Given this list of marker genes CD74, PHF13, GLCE, BLTP1, INTS15, SENP6, IER5, ZFP62, TRIM33, FASTKD2, NFKB2, TAP1, TOR1AIP2, CLMP, IQGAP2, GBP6, ADORA2A, NUBPL, IL1RN, IL36A, SPATA2, HDC, VEZF1, TNNI3, IL15, C10orf88, TAF7, UTP20, E2F5, HMGN5, ORM1, POLR1F, SNN, PES1, EIF3D, CSF1, AMMECR1L, MECR, ARF1, RPS6KA5, RPS6KA2, MED21, BAZ1A, CH25H, PTPRC, CYTL1, FUS, CLIC4, MRPL10, SRRM2, SFR1 (NCBI Gene Id 119392), ARSG, COG3, MIR22HG, LAMC2 (laminin subunit gamma 2), NFKBIE, HSPA1L, JDP2, NDUFS1, ATF6B, CALHM6, ING3, ANKRD11, MTMR12, GBP7, DNAJC1, CLCN7, ENPP4, RELB, FGG, TES, FSCN2, TTC5, ADCY10, LONP1, TRAK2, CCSER2 (coiled-coil serine rich protein 2, NCBI Gene Id 54462), ZRANB1, PHLDA1 (pleckstrin homology like domain family A member 1), LRCH1, SNRPB, RAVER1 (ribonucleoprotein, PTB binding 1, NCBI Gene Id 170590), ZNF800, LENG1, GAB2, ANTXR1, PRSS46P, KMT5A, MSANTD4, MRPL50, CDKN1A, SLC25A37 (NCBI Gene Id 55881), IL1RAP (interleukin 1 receptor accessory protein), MDM2, KCNE4, CPSF7, RDH13, HBP1, CHIC2, HS6ST2, NGLY1, RAD18, SAP30, MAP2K4, DCAF12, CLOCK, HIVEP3, TXNL1, CISH, TLR1, MAP3K8, JUND, FBXO34, UFM1, MED19, SUN2, SLC30A6, NCK1, GUCD1, MCOLN2, CCDC157, CGAS, ADGRD1, NSUN5, MAPK1, NOP14 (NCBI Gene Id 8602), NFKBID, IPO7, RIMOC1, ADORA2B, CLBA1, RNF4, TSHZ1, ZNF827, ELF2, TIMM23, UBQLN1, CTDNEP1, CSF3 (colony stimulating factor 3), NDST1, PEX16, SUPT7L, TMF1, ZNF655, PHF12, CHD2, RNF180, RABAC1, CASKIN2, NFKB1 (NCBI Gene Id 4790), KDELR1, OSM, COL18A1, F2R, TBC1D1, IL12B, BLZF1, NAP1L4 (nucleosome assembly protein 1 like 4), PAK4, ETS1, CLEC4E, FAM120AOS, EIF2S2, HMGB2, FLNB, KCMF1, RNF146 (NCBI Gene Id 81847), SLC20A1, TMEM161B, MERTK, UBL4A, PRPS1L1, MAK16, TTC32, UBXN7, HERC6, INPP5E, PSMA4, MED12, TIMM50, SLC2A6, OAT, TBRG1, APPL1, TPR, PPP3CC, ATF2, CCL7, ZNF397, S100G, EREG, MX1, NUP93, PTPN12, ZBTB7A, SMARCC2 (SWI/SNF related, matrix associated, actin dependent regulator of chromatin subfamily c member 2), RNF24, TAF11, CXCL3, PRF1, here is a description of the gene set: from publication Koziczak-Holbro M, Glück A, Tschopp C, Mathison JC, Gram H (PMID 18266302) IRAK-4 is an essential component of the signal transduction complex downstream of the IL-1- and Toll-like receptors. Though regarded as the first kinase in the signaling cascade, the role of IRAK-4 kinase activity versus its scaffold function is still controversial. In order to investigate the role of IRAK-4 kinase function in vivo, ‘knock-in’ mice were generated by replacing the wild type IRAK-4 gene with a mutant gene encoding kinase deficient IRAK-4 protein (IRAK-4 KD). Analysis of bone marrow macrophages obtained from WT and IRAK-4 KD mice with a number of experimental techniques demonstrated that the IRAK-4 KD cells greatly lack responsiveness to stimulation with the Toll-like receptor 4 (TLR4) agonist LPS. One of the techniques used, microarray analysis, identified IRAK-4 kinase-dependent LPS response genes and revealed that the induction of LPS-responsive mRNAs was largely ablated in IRAK-4 KD cells. In summary, our results suggest that IRAK-4 kinase activity plays a critical role in TLR4-mediated induction of inflammatory responses. Human Gene Set: GSE9037_WT_VS_IRAK4_KO_LPS_4H_STIM_BMDM_UP studied in species Homo sapiens Genes up-regulated in comparison of wild type macrophage treated with LPS (TLR4 agonist) at 4 h versus those from IRAK4 deficient mice treated with LPS (TLR4 agonist) at 4 h.